Given this list of marker genes PRNP, ITPR1, RYR1, SLC25A31, CASP3, ITPR2 (inositol 1,4,5-trisphosphate receptor type 2), RYR2, ITPR3, VDAC3, VDAC1, CYCS, SLC25A4, MCU, CASP9, SLC25A6, RYR3, SLC25A5, APAF1, VDAC2, here is a description of the gene set: Pathway Definition from KEGG: PRNP* -> (RYR,ITPR) -> Ca2+ -- MCU -> Ca2+(mito) -- MPTP -> CYCS == APAF1 -> CASP9 -> CASP3 studied in species Homo sapiens Scrapie conformation PrPSc to mGluR5-Ca2+ -apoptotic pathway. Pathway ID: N01199. Pathway type: Variant. Pathway class: nt06465 Prion disease. Human Gene Set: KEGG_MEDICUS_VARIANT_SCRAPIE_CONFORMATION_PRPSC_TO_MGLUR5_CA2_APOPTOTIC_PATHWAY